Given this list of marker genes GDNF, LHX1, PAX8, PAX2, PROM1, CD24, LIF, here is a description of the gene set: Any process that activates or increases the frequency, rate or extent of epithelial cell differentiation involved in kidney development. Human Gene Set: GOBP_POSITIVE_REGULATION_OF_EPITHELIAL_CELL_DIFFERENTIATION_INVOLVED_IN_KIDNEY_DEVELOPMENT studied in species Homo sapiens